Given this list of marker genes MIR124-3, FADS1, MIR92A2, IGF2R, PICALM, PHC2, LPL, CEBPB, CYP1B1, SRSF9, SRSF10, ELOVL5, TGFBR2, MIR29C, TMED10, MIR27B, MIR106B, MIR1-2, MIR16-2, MIR30A, MIR30C1, TMEM43, MIR1-1, MIR16-1, MIR30E, MIR30D, MIR30B, HIPK3, MIR124-2, CAP1, MIR30C2, MIR20A, CSRP1, here is a description of the gene set: species: Homo sapiens Human Gene Set: WP_MIRTARGETED_GENES_IN_ADIPOCYTES miR-targeted genes in adipocytes